Given this list of marker genes Comt, Pde1b, Dhps, Smox, Hnmt, Sult1a1 (NCBI Gene Id 20887), Paox (NCBI Gene Id 98263), Dmgdh, Moxd2, Sat1, Maoa, Atp2b4, Moxd1, Slc6a3, Dbh, Tomt, Maob, here is a description of the gene set: species: Mus musculus The chemical reactions and pathways resulting in the breakdown of any organic compound that is weakly basic in character and contains an amino or a substituted amino group. Amines are called primary, secondary, or tertiary according to whether one, two, or three carbon atoms are attached to the nitrogen atom. Mouse Gene Set: GOBP_AMINE_CATABOLIC_PROCESS